Given this list of marker genes OLR1, RPS27A, CD34 (CD34 molecule), ANGPTL4, SELE, here is a description of the gene set: Human Gene Set: SMIRNOV_CIRCULATING_ENDOTHELIOCYTES_IN_CANCER_DN studied in species Homo sapiens Increased numbers of endothelial cells are observed in peripheral blood of cancer patients. These circulating endothelial cells (CECs) may contribute to the formation of blood vessels in the tumor or reflect vascular damage caused by treatment or tumor growth. Characterization of these cells may aid in the understanding of the angiogenic process and may provide biomarkers for treatment efficacy of angiogenesis inhibitors. To identify markers typical for CECs in cancer patients, we assessed global gene expression profiles of CD146 immunomagnetically enriched CECs from healthy donors and patients with metastatic breast, colorectal, prostate, lung, and renal cancer. From the generated gene profiles, a list of 61 marker genes for CEC detection was generated, and their expression was measured by real-time quantitative PCR in blood samples from 81 metastatic cancer patients and 55 healthy donors that were immunomagnetically enriched for CECs. A set of genes, among which novel CEC-associated genes, such as THBD, BST1, TIE1, POSTN1, SELE, SORT1, and DTR, were identified that were expressed at higher levels in cancer patients compared with healthy donors. Expression of the VWF, DTR, CDH5, TIE, and IGFBP7 genes were found to discriminate between cancer patients and healthy donors with a receiver operating characteristic curve accuracy of 0.93. Assessment of the expression of these genes may provide biomarkers to evaluate treatment efficacy. Genes down-regulated in circulating endothelial cells (CEC) from cancer patients compared to those from healthy donors. from publication Smirnov DA, Foulk BW, Doyle GV, Connelly MC, Terstappen LW, O'Hara SM (PMID 16540638)